The following is a description of a gene set: part of: Infectious disease Reactome Pathway: Viral Infection Pathways Viral infection pathways aim to capture molecular mechanisms of human viral diseases related to viral adhesion and penetration of human host cells, viral genome replication and synthesis of viral proteins, interaction of viral proteins with the proteins of the human host, and evasion of the host's immune defense.<br><br>Viral infection pathways currently include the life cycles of SARS-CoV viruses, influenza virus, HIV (human immunodeficiency virus), and human cytomegalovirus (HCMV).<br><br>Newly discovered coronaviruses SARS-CoV-1 and SARS-CoV-2 cause severe acute respiratory syndrome (SARS). These viruses belong to the family Coronaviridae, characterized by the presence of lipid envelope and genome in the form of single-stranded, linear, nonsegmented, positive-sense RNA.<br><br>Influenza viruses, the causative agents of flu, belong to the family Orthomyxoviridae, characterized by the presence of lipid envelope and genome in the form of single-stranded, segmented, negative-sense RNA.<br><br>Human immunodeficiency viruses (HIV), the causative agents of acquired immunodeficiency syndrome (AIDS), belong to the genus Lentivirus, family Retroviridae, characterized by the presence of lipid envelope and genome in the form of single-stranded, nonsegmented, linear, diploid, positive-sense RNA that produces a DNA intermediate during viral replication. Namely, retroviral RNA-directed DNA polymerase (reverse transcriptase) transcribes genomic RNA into viral DNA that integrates into host cell's DNA as a provirus.<br><br>Human cytomegalovirus (HCMV), one of the causative agents of infectious mononucleosis and pneumonia, belongs to the the family of herpesviruses (Herpesviridae), characterized by their large size, presence of lipid envelope, and genome in the form of linear double-stranded DNA that encodes more than a hundred different proteins. species: Homo sapiens, and this is the list of marker genes: RCAN3, EIF4G2, TAF3, STING1 (NCBI Gene Id 340061), MED10, ISG15, RPS15A, TRAF6, UL54, RPL35, RPS28, SRSF11, STT3B, SRSF4, GALNT1, CD79B, DHX9, SFN, RPL10A, POLR2C, ST6GALNAC3, KPNA4, IGLV3-21, RPL23, RPS23, GSK3B, ELOA2, PQBP1, H2AC20 (H2A clustered histone 20), S1PR1, ADRM1, GBF1, EGFR, 9b, RPS21, NMT2, PPIH, UL114, IGKV3-15, MED17, BCL2L1, IFNA8, CX3CR1, IGHV, PPIB, TUBA4B, XRCC4, US32, SRSF1, VTA1, ANO7, ACE2, RBX1 (NCBI Gene Id 9978), ZDHHC3, PLCG2, gH, US20, TLR3, RPS15, HLA-A, HLA-B, MTOR, NFKB1, UL11, APOBEC3G, CNBP, RPS26, TJP1, US22, RL10, PDPK1, NUP210 (nucleoporin 210), CPSF1, PPP1CA (protein phosphatase 1 catalytic subunit alpha), ACOT2, SCAP, CD300A, 1B, TRIM4 (tripartite motif containing 4), IGKV2-29, VPS36, GOLGA7, HNRNPUL1, PDCD1, F, PHF21A, PSMD13, BTK, ALYREF, RL8A, UL122, CEBPD, YWHAB, HSPA5, IGKV2D-30, UBA1, AP2A1, MAN1B1, IGLV2-14, UL87, nef, RPL3L, YWHAQ, DPM2, UL5, gag-pol, IFNB1, MED1 (mediator complex subunit 1), RPS25, POLR2L, ATP1A1, CTR9 (NCBI Gene Id 9646), AP1S3, NPLOC4, UBE2I, SNRPE, GRPEL1, CHMP4C, RAB5A, GEMIN6, US33A, IFIH1, IGKV2D-28, CD8B, NA, RPLP2, TUBA1A, G, SNRPB2, MGAT2, YWHAE, AUP1, MED14, BCAP31, BLNK, HNRNPL, VPS37D, ARIH1, MAVS, LIG1, TAF15, LYN, ATP1A4 (NCBI Gene Id 480), 6, IRS1, IGKV2D-40, EED, UL36, TAF11, CHMP7 (charged multivesicular body protein 7), SKP1, TAF10 (TATA-box binding protein associated factor 10), CHD4, UBA6, FXYD4, PB2, UL26, UBR4, NFKBIB, RTF1, TSG101, PEX19, UBA7, PAPOLA, CD4, KDELR1, RBBP4, CALR (calreticulin), EIF4G1 (NCBI Gene Id 1981), H2BC3, UBB (NCBI Gene Id 91253), HNRNPK (heterogeneous nuclear ribonucleoprotein K), NUP205, vpr, ZDHHC5, TMEM258, MAGT1, NELFB, DAD1, PACS1, VCP, TAF13, ST3GAL4 (ST3 beta-galactoside alpha-2,3-sialyltransferase 4), ST3GAL3, H2BC9, CHUK, CSNK1A1, RPN2, IGHV3-53, VPS33B, SRSF9, H2AC14, BUD31, CVC1, RPS4Y2, SRSF2, PTPN11, SLC25A5, UBE2N, PPIL1, GEMIN2, UL13, RPL23A, FXYD1, vif, UL70, IGHD, POLR2J, H2BC11, PSMA4, U2SURP, CDK8, PSMD7 (NCBI Gene Id 5713), VPS4A, PARP9, SYK, HNRNPA1, SNRNP40, HDAC1, SUZ12, PALS1, IGF1R, CAMK2D (NCBI Gene Id 817), IFNAR2, TCEA1, GSK3A, RBM5, IGKV4-1, NUP93 (NCBI Gene Id 9688), SEC24D, 1C, H3C15, PPIG, UL82, PSMB7, NMT1, MGAT4A, IFNA10, FXYD6, GBP1, SRPK1, PABPN1, RPL39L, SEC13, NPM1, SNF8, RBM22, HMGA1, SLC25A4, SEC24C, IKBKG, TMPRSS2, ANO4, MED13L, SNRPD1, CLDN1 (claudin 1), RPTOR, RPL37A, SDC4, RRBP1, UBA5, CSTF3, CDK7, H2AC4, UL37, 7a, NFKBIA, IGKV5-2, HLA-H, HNRNPA2B1, POLR2F, CSNK2A2, CSTF2, H2AC25, TLR6, EP300, HDLBP, NEC1, AP1S2, RPSA, IRAK2, IGHV4-39, RIGI, PTGES3, CRNKL1, CHMP1A, SUN2, UL21A, RPL22, YWHAG, GJA1, NCBP1, CAMK2B, POLR2G, GATAD2B, UBC, MED11, IGLV6-57, TAF9 (TATA-box binding protein associated factor 9), EIF4A1, RPLP1, PLRG1, GTF2A1, MTA1, UL14, RNPS1, IL17F, STAT2, PIK3R1, US28, IFNA17, DYNLT1, SF3B1, BANF1 (barrier to autointegration nuclear assembly factor 1), TAF5, DDX46, BRD4, IMPDH2, UL102, NUP98, CLINT1, HNRNPU, PATJ, CTNNBL1, SF3B6, RPL7, SF3A2, RPS3, 3b, IGHV4-34, AP2B1, CLTC, DDX20, UL69, gN, IGLV2-8, SF3A3, PPIL6, P4HA1, LY6E, H2BC14, ATP1A2, POLR2K, CD79A, VPS4B, JAK1, DOCK2, IGHV1-69, PARP10, SNRPG, IFNA2, RL11, ISY1, GATAD2A, NUP43, RTN3, PCBP2, ARF1, MOGS, H2AC11, TAL1, NR3C1, TLR2, DENCMEMSB, GPC2, CBX1, POLR2B, UL120, NELFCD, SNW1, CPSF2, UL148, VEGFA, UL32, UL94, H2BC4, 5.8S rRNA, RAN, CSNK2B, PRPF8, 7SL RNA (ENSG00000222619), CCNT2, SRSF7, IFNA1, RPS4X, RPL7A, RPS18, RPS20, H2AC6, SPCS1, ROCK2, FAU, US13, PAK2, M2-1, PSMA7, Human respiratory syncytial virus A, 18S rRNA, RANGAP1, IL1R1 (NCBI Gene Id 3554), MVB12A, CHMP2A, IGHV3-30, HLA-C, FUS, IL17A, PSMD11 (NCBI Gene Id 5717), RPL15, 3a, ITCH, UL74, US26, IGHV4-59, FEN1, SRSF5, RPS8, RPL34, ANO10, TIMD4, MLST8 (NCBI Gene Id 64223), RPS4Y1, CWC22 (CWC22 spliceosome associated protein homolog), NCOR2, C4BPB, IRF3, SSRP1, UL112/UL113, SNRPF, TAF2, MED18, US24, PSMD12, H2AC18, AKT3, PB1, XRCC6, MLKL, IGHV1-2, VPS18, 28S rRNA, PRKCSH, DNAJC3, RPS27A, FKBP1A, NUP58, IFNA14, GTF2F2, CAV1, CCNH, UL146, PSMD8, UBA52, ARID4A, TAF8, BRMS1, ZDHHC20, CTDP1, PRPF19, POM121C, RETREG1, CLEC5A (C-type lectin domain containing 5A), IGKV1D-16, RPL18 (NCBI Gene Id 6141), PSMA2, TUBB4B, PSMD2, EMC4 (ER membrane protein complex subunit 4), SP1, EIF4A2, MED28, PSMB6, P, US16, TXNL4A, FXYD7, REST, PSIP1, ATP1B1, NUP107, TUBB8, IFNA21, MED29, LIG4, DPM3, RPL41, RIPK3, SEC24A, NCBP2, UL18, RBM17, GANAB, CRB3, IFNAR1, US34A, TBP (NCBI Gene Id 6908), TAF7, JAK2, CD209, H2AC7 (NCBI Gene Id 3013), H3C1, RNF135, PUF60, env, TBL1X, MED16, CYSLTR1, WBP11, UL22A, FXYD3, gB, RPL36, RPS24, HLA-F, RPL29, RPL24, S, TAF7L, TYK2, IGLV1-40, NCK1, PSMB5, POLR2I, VPS16, US2, TUBA3C, RPL21, ERCC3, POLR2H, TLR7, RPL10, MED19, DYNLL1, RL1, MAP1LC3B, SAP30L, DNAJA2, ANO6, CUL3, VIM, NFE2L2, GTF2H5, RPL8, RAB5B, IGLV3-27, PRKG1, CCNT1, VPS45, VPS37A, NUP88, GTF2A2 (NCBI Gene Id 2958), HSPG2, UL48, FUT8, XRCC5, SMN1, RPL22L1, IKBKE, AP2S1, GRSF1, BECN1, SNRPA1, UL7, RNGTT, UL43, CGAS, IFNGR2, ELAVL2, CHMP3, L, TUBB2B, CD28, MAPRE3, HA, LEO1 (NCBI Gene Id 123169), ATP1B2, IGHV2-5, SIGMAR1, Hh5 strain Merlin complete genome, IGKV1-17, CLU, ZDHHC8, CTNNB1, IPO5, SMNDC1, P4HA3, IGLC7, H2BC21, SUDS3, CREB1, RPS27L, CCAR1, MAPKAP1, HNRNPM, MED24, KPNA2, IGKV1D-33, PARP14, ITGB1, UL15A, MVB12B, SRRT, MED30, IGKV1-5, SEC24B, PPP1CC, NUP62, NDC1, UBA3, NUP155, IGKV3-11, RPS13, GPC1, NLRP3, PPIL4, gM, KDM1A, HNRNPF, TLR9, PIK3C3, RUNX1, MGAT4B, H2BC18, U2AF1L4, ZDHHC2, PPIL3, HNRNPA0, PSMD1, RAC1, BST2, ST6GAL1, NUP50, HDAC3, AKT1, RPL9, MNAT1, UL41A, RPN1, MED7, NUP160, PDIA3, RPS17, IGLV2-11, IGHV3-33, PRPF6, CDC40, IFNA7, HNRNPC, TUBB6, IGHV3-13, PCF11 (NCBI Gene Id 51585), SERPINE1, IGKV1-33, DHX15, G3BP1, CLEC4M, NOD1, APOA1, PSMC3, N, RPS6, AP1B1, MED26, PIK3R4, NUP214, RBBP7, MERTK, IGLC6, GTF2E2, TUBA1B, VPS28, TUBB, H2AC21, TBL1XR1, UL91, PSMB1, DHX16, SUPT4H1, RPL28 (ribosomal protein L28), RBM10, CHMP4A, TKFC, IGHV3-48 (immunoglobulin heavy variable 3-48), TRX1, KPNA5, rev, FYN, SNRPD2, NLRP12, HYOU1, UL144, GPC5, XAB2, SDC1, CSTF2T (NCBI Gene Id 23283), ATP1A3, E, SH3KBP1, IGHV3-7, MED12 (mediator complex subunit 12), HSPA8, NEC2, AKT2, RPL26L1, MED31, UL104, CDK9, UL34, IGKV1-12, TRM3, HLA-E, BAG2, HSP90AB1, RANBP1, SPCS3, RPL6, SF3B4, IGKV2-30, SRSF3, UL24, VPS11, RNMT, POLR2A, VPS41, AXL, MED4, TUBB2A, MED20, GTF2H1, CDC73, MAP1B, TUBB4A, C1S, SEH1L, HNRNPD, TPR, HERC5, ANO1, IGHV7-81, EIF4A3, RPL36AL, PDCD6IP, US19, TUBA4A, IGHV2-70, AAAS (aladin WD repeat nucleoporin), RL9A, gL, SDC3, UL35, SLC25A6, KEAP1, RIR1, IGLC3, RPL13, IMPDH1, UL96, CD14, PARP1, tat, US11, DYNC1LI2, UL27, C4A, CCR5 (NCBI Gene Id 727797), NP, GTF2H3, SOS1, RPL30, H4C1, ST6GALNAC4, IGLV3-25, UL4, RPL3 (NCBI Gene Id 6122), TLR8, rep, H2AC12, UL29, TRX2, RPL27A, UL99, ANO2, RPS7, RPS19, PKLR, PARP8, pp1a, UL147, ST3GAL2, ELOC, VTN, RPL12, CCNK, LARP1, RPL19, SIKE1, PHF5A, SDC2, UL98, IL17RA, AP2A2, CAMK2A, MGAT5, IGHV3-23, RPS14, DNAJC8, CHERP, RPS27, SRSF6, KPNA1 (NCBI Gene Id 3836), UL47, H2BC26 (NCBI Gene Id 128312), UL17, IGLV1-51, DDOST, UL16, 8, HLA-G, TOMM70, RIPK2 (receptor interacting serine/threonine kinase 2, NCBI Gene Id 8767), GPKOW, RPL18A, SRRM1, US23, TRIM25, DYNC1I1, FXYD2, ZDHHC11, ITGA4 (integrin subunit alpha 4), MED9, ATP1B3, ANO8, SAP30, VPS37B, SEC11A, G3BP2, H2BC12, H2BC1, ROCK1, NUP153, HSPA1B, IGLV, SMAD3, H2AC1, MGAT1, TUBB1, XRN1, MAP3K7, UL71, CTSL, RICTOR (NCBI Gene Id 253260), RPL26, IFNA5, EDEM2, TAF1, IGKV3D-20, MED13, EIF2AK2, MED27, MED8, AP2M1, UL83, DYNLL2, PTPN6, UL117, RPS11, RPL14, TUBA3D, FASN, BTRC, GTF2B, IGLV1-44, MASP2, NRBP1, PSMC1, MAN2A1, CLTA, C1QA, UL2, CSNK2A1, RPL10L, SEM1, F2, PA, MTA3, PSMB4, IGLV1-47, TRM2, DNAJB11, TAF12, SCP, NPIPB3, TLR4, SYMPK, US27, GTF2F1, KPNA7, HELI, KPNA3, PARP16, AQR, CVC2, H2BC13 (NCBI Gene Id 8340), CANX, GPC6, NCL, HNRNPA3, MBL2, H2BC15, SUMO1, XPO1, UL147A, ERCC2, JAK3, UFD1, PPIE, FURIN, UBE2L6, GTF2E1, DUT, AP1M1, DPM1, FIP1L1, UL92, CLP1, IFNA16, CDK19, UL79, ELL, PCBP1, GEMIN7, MRC1, CWC15, GPC4, HCK, SUPT16H, IGLC1, ST6GALNAC2, DDX5, DAXX, CD247, RPL17, IFNGR1, B2M (beta-2-microglobulin), UL103, TUFM, PSMB2, PTBP1, WDR33, MGAT4C (NCBI Gene Id 25834), US12, RPL31, IGLV2-23, FNTB, H2BC17, YBX1, US34, NELFE, H2BC5 (NCBI Gene Id 3017), SNRPN, IGHV1-46, PSMC4, TUBA8, RAB5C, ATG7, PSMC6, Human respiratory syncytial virus A2, complete genome, MED6, UL88, RANBP2, BCAS2, NUP37, CREBBP, P4HB, DYNC1LI1, VPS25, SKIC8, vpu, IGKV2-28, ANO5, US10, UL38, PYCARD, NUP188, NEDD4L, UL23, RPL27, UVRAG, IGKV1-39, IGKV1D-12, SMAD4, TAF9B, DHX38, SRRM2, EIF4E3, CPSF6, CHMP6, IGLC2, DYNC1H1, RPS29, ZDHHC9, VAV1, MTA2, gag, SF3B3, UBAP1, RPL11, NEK2, ATG14, EEF1A1, RBMX, MBD3, ST3GAL1, DBP, IGLV3-19, RPS12, GPC3, UL78, ELAVL1, SARS coronavirus, complete genome, U2AF2, RNASEK, UL123, TUBB3, COG1, NRP1, IGKV1-16, RPS9, RPL35A, RB1, CUL5, PPIA, MED23, 7SL RNA (ENSG00000222639), TUBA3E, NELFA, TYRO3, PSMD6, RNA4.9, TUBA1C, UL84, PRR5, ISCU, DNAJC10, P4HA2, 8b, AP1M2, SFTPD, UL31, GPS2, US3, PSMC5, STAT1, NOD2, POLR2E, UL52, CHMP5, LCK, PSMA3, GTF2H2, TRAF3, ELK1, IGLV3-1, IRF7 (interferon regulatory factor 7), TUBAL3, IGKC, 1a, CCNC, NUP133, PML, M, HNRNPH2, TUSC3, PRKG2, GEMIN5, MED15, EIF4G3, RPS3A, RPS10, HNRNPH1, TAB2, CWC27, DDX42, VPS37C, SNRPD3, YWHAH, VHL, RCC1, 5S rRNA, BTF3, NUP35, PARP4, SH, CDC5L (cell division cycle 5 like), TAF4B, CHD3, SF3B2, PRMT1, AGRN, SUPT5H, UL131A, SNRPB, TAB3, IFNA4, RELA, HNRNPR, NS5B, UL124, AP1G1, UBE2V1, TAB1, UL132, SUGP1, RPL37, DDX3X, EFTUD2, ATP6V1H, PRCC, IGHV3-9, PARP6, TRS1, CHMP4B, C4BPA, YWHAZ, CPSF4, HMG20B (high mobility group 20B), UL119/UL118, CD33, US8, SAR1B, ELOB, CAMK2G, ZCRB1, PSMA1, RPL13A, OAS2, PSMD3, IKBKB, CD2BP2, NUP42 (nucleoporin 42), GRB2, TAF6, RCOR1, RPL36A, GAS6, EZH2 (enhancer of zeste 2 polycomb repressive complex 2 subunit), HSPA1A, CSTF1, HDAC2, TRM1, KPNB1, TLR1, TAF4, M2-2, VPS33A, TRIM28, IPO7, UL76, SNRNP200, MASP1, STT3A, ZBP1, UL121, SF3A1, RPL38, SEC11C, UL9, MED25, NUDT21, SEC23A, FKBP4, UL44, US18, IGLV7-43, RIPK1, AP1S1, MED21, PABPC1, IL6R, PSMA5, UL111A, C4B, UL138, US14, RPS2, US9, PAF1, US30, U2AF1, CHMP2B, PSMC2, CPSF7, NUP54, NS, SRPK2, MCP, PSMD14, UL97, TBK1, IGKV1D-39, PSMB3, ANO9, IGKV3-20, NUP85, RPL5, NACA, EXOC1, UL25, MED22, GEMIN8 (gem nuclear organelle associated protein 8), HAVCR1, EIF4E, HSP90AA1, POM121, ANO3, IL17RC, US17, CXCR4 (C-X-C motif chemokine receptor 4), RPL32, ELMO1, IFNA6, MMP9, IRAK1, RAE1, SAP18, IGHV3-11, NCOR1, TGFB1, OSTC, SPCS2, UL95, PPP1CB, CPSF3, RPS5, TUBB8B, CASP1, OST4, LY96, POLR2D, GTF2H4, FNTA, IGHM, SF3B5, DYNC1I2, ATL2, UL130, CRBN, UL80, RPL4, ELOA, ARID4B, DDX23, RPS16, RPL39, RPLP0, TAOK1, CWC25, UL133, NMI, PSMA6, TAF1L, GEMIN4, COMT, VPS39, PROS1